The following is a description of a gene set: Genes predicted to be targets of miRBase v22 microRNA hsa-miR-6813-5p in miRDB v6.0 with MirTarget v4 prediction scores > 80 (high confidence targets). species: Homo sapiens Human Gene Set: MIR6813_5P from publication Chen Y, Wang X (PMID 31504780), and this is the list of marker genes: MUC1, PLXNA1 (NCBI Gene Id 84202), SMG6 (NCBI Gene Id 80091), ERCC1, VAV2, GNA12, FAM222B, FTO, DCX, HEATR5B, NDUFA6, NPAS2, ZDHHC9, CPEB2, SYNPO, ZFAND2B, RPL22L1, DCAF8, ATCAY, KCNN2, ENC1 (NCBI Gene Id 8507), ZFHX4, BET1, SNX12, APP, BAP1, MAPKBP1, HCCS, SOX10, TRH, TFB1M, PGRMC2 (progesterone receptor membrane component 2), ELMO1, PDAP1, HSD17B12, ZNF664, KLK4, TOX4, C1QTNF1, ZNF74